Given this list of marker genes PLCB2 (phospholipase C beta 2), SLC25A5, MCU, CYCS, ATXN3, SLC25A4, ITPR1, ATXN2, SLC25A6, SLC25A31, VDAC1, VDAC3, VDAC2, PLCB4, PLCB1, GNAQ, GRM1, PLCB3, here is a description of the gene set: Mutation-caused abberant ATXN2/3 to mGluR5-Ca2+ -apoptotic pathway. Pathway ID: N00957. Pathway type: Variant. Pathway class: nt06462 Spinocerebellar ataxia. Pathway Definition from KEGG: Glutamate -> GRM1 -> GNAQ -> PLCB -> IP3 -> (ITPR1+(ATXN2*,ATXN3*)) -> Ca2+ -- MCU -> Ca2+(mito) -- MPTP -> CYCS studied in species Homo sapiens Human Gene Set: KEGG_MEDICUS_VARIANT_MUTATION_CAUSED_ABBERANT_ATXN2_3_TO_MGLUR5_CA2_APOPTOTIC_PATHWAY